The following is a description of a gene set: We employed a proteomic strategy developed to characterize the in-vivo ECM composition of normal tissues and tumors using enrichment of protein extracts for ECM components and subsequent analysis by mass spectrometry. We grew subcutaneous tumors by injection into NOD/SCID/IL2R? mice of A375 human melanoma cells (poorly metastatic) or their highly metastatic derivatives MA2. The tumors were dissected 5 weeks later, and the tumor ECM was enriched and analyzed using mass spectrometry. We define the tumor ECM as the ensemble of ECM proteins and ECM-associated proteins found in two independent samples. A challenging question when studying the tumor microenvironment is to understand the origin of the tumor ECM; that is, whether the tumor ECM is produced and secreted by the tumor cells themselves, by the stromal cells or by both compartments. To address this question, we pursued the analysis of the melanoma xenografts described above, by identifying the origin of each protein. In order to be able to identify without ambiguity the origin of each protein, we required that proteins needed to be detected in two independent samples with at least two species-specific peptides in one of them. Using this strategy, we identified for each tumor type a set of matrisome proteins exclusively secreted by the (human) tumor cells, and another set exclusively secreted by the (murine) stromal cells. This gene set lists the matrisome proteins (based on the criteria mentioned above) secreted by the tumor cells in A375 tumors and not in MA2 tumors. species: Homo sapiens Tumor-derived matrisome proteins exclusively detected in poorly metastatic melanoma human-to-mouse xenografts (A375) in comparison to highly metastatic melanoma human-to-mouse xenografts (A375_MA2). Human Gene Set: NABA_MATRISOME_POORLY_METASTATIC_MELANOMA_TUMOR_CELL_DERIVED from publication Naba A, Clauser KR, Hoersch S, Liu H, Carr SA, Hynes RO (PMID 22159717), and this is the list of marker genes: P3H3, LMAN1, ECM1, THSD4, TGFB1 (NCBI Gene Id 7040), COL18A1, CD109, ANXA2, S100A4, SERPINB1, S100A6, ANGPTL4, HCFC1, S100A13 (S100 calcium binding protein A13), COL4A4, SRPX, PLOD3, PLOD2, LOXL2 (lysyl oxidase like 2), BGN, HTRA1, CTSB, ADAMTSL1, P4HA1, LGALS3, SERPINF1 (serpin family F member 1)